Given this list of marker genes SOCS1, UCP2 (NCBI Gene Id 7351), KCNQ1, TEK, IRF7, MYC, FCER1G, CBFA2T3, TFRC, MR1, KMT2A, IFNG, SMAP1, CDK6, EOMES, RHOH, USP44, LEF1, IGHM, ZFPM1, CD8A, DYRK3, DHRS2, MIR145, ARL11, HERC6, XRCC6, TTC7A, MFAP5, LOXL3, TGFBR2, SIRT1, FLNA, SHB, IL1A, BCR, MPL, PPP3CB, PRRC2C, FOXN1, SRC, TMOD3, RAG2, PRKDC, TNFSF8, EXT1, ZBTB7A, TCF3, PITHD1, CDH17, SOX4, FBN1, GAB2, ITGB1, PGLYRP3, IL36B, RC3H1, EVI2B, RAG1, IL23R, DUSP10, BCL6, ZNF160, ITPKB, WNT2B, EPO, SNRK, GPR137B, ADAM10, SPINK5, SH3PXD2A (SH3 and PX domains 2A), CD109, G6PD, IL12B, JAK1, MITF, HES1 (hes family bHLH transcription factor 1), SOS1, LRRC17, CHD2, ITPRIPL1, IL15, QKI, AICDA, SMARCD1, FZD8 (NCBI Gene Id 8325), MALT1, BTK, TNFSF4, CD1D, TPO, ASH2L, EBP, SIGLEC15, IL17D, HCLS1, PTPRJ, PLA2G10, MFAP2, BMP2, STAT5B, GLI2, ACP6, LYAR, BCL3, FOXO3, TREX1, ATF2, ACVR2A, KITLG, ITFG2, ADD2, MEIS1, PPARG, TOX, AGPAT5, DLL4, MFHAS1, CD34, BGLAP, CRIP2, PLA2G3, PIK3R3, EEIG1, RARG, EZH2, SBDS, BAD, TNF, HLX, CARTPT, ACVR1B, FOXC1, FAM20C, NF1, ATP6AP1, DCAF1, SMARCD2, FSTL3, GP9, MYO1E, ACTB, IL2RA, MED1 (mediator complex subunit 1), DMTN, TCIM, FLI1, PRKCA, CEBPA, IL9, BAK1, METTL3, CD79A, IL7R, C1QC, PCID2, IFNB1, IL6ST, SYVN1, LAPTM5, SFRP2, PLCG2, HLA-G, FBXW7, KDELR1, PIK3R2, LEO1, CD164, IL33, LTF, HLA-DOA, SIPA1L3, CCDC134, RPL22, EIF6 (eukaryotic translation initiation factor 6), COX10, SIN3A, LY6D, IL15RA, PTPN6, IRF2BP2, FAXDC2, PNP, ANKLE1, RHOA, RAC2, ARIH2, IL1RL1 (NCBI Gene Id 9173), FSHB, SMAD7, JUN, CCR9, KLF2, MIR222, ID2, PREX1, HIF1A, CTSL, PPP3CA, FBXO21, EIF2AK2, L3MBTL3, ARMC6, WNT3A, SLC46A2, B2M, RIPK1, RC3H2, PRTN3, DNAI4, GLRX5, HEATR3, TSC1, MYSM1, SOCS3, RBM15, WDR38, METTL14, CITED2, FGL2, SMARCE1, ITGB8, ATG5, KIT, BCL2, DHTKD1, LILRB3, TGFBR3, ANLN, IL1B, PTGER4, VPS33B, GFI1B, IRF8, MECOM, PRXL2A, TLR3, BVES, TRIM58, MIR486-1, RIPK3, REST, IL6, ENTPD7, PSEN1, ZNHIT1, GPR68, ZFP36L1, IL18R1, CLEC4D, LDB1 (NCBI Gene Id 8861), RACGAP1, ACIN1, NBEAL2, ADGRF5, THEMIS, CCDC39, CARD11, CD4, TYROBP, TRPM2, EFNA2, MKNK2, H4C9, IL17A, GPR183 (G protein-coupled receptor 183), TMEM176B, MAPK11, SART3, IGHE, FNIP1, CEBPB, POLM, CLEC1B, PTCRA, ADAM8, MEIS3, IHH, SFRP1, MEOX1, GP1BA, NPM1, GPR137, EGR1, PIK3CD, NOTCH4, RBM47, VEGFA, CLEC5A, NDFIP1, RORA (RAR related orphan receptor A), ARID4A, EIF2AK1, KAT5, KLF4, IL27, PIM1, APCS, CD46, CCR2, LARGE1, CTC1, SKIC8 (NCBI Gene Id 80349), NDP, MIR125B1 (NCBI Gene Id 406911), HDAC4 (NCBI Gene Id 9759), ICOSLG, MERTK, TSPAN2, IL1RL2, HIPK2, DPF2, H4C6, HMGB3, NKAP, AGER, CSF3, CD3G, NR3C1, SSBP3, CCR6, FANCA, SASH3, EGR3, RUNX1, CD80, ANG, HMGB2, TESPA1, LGALS3, SLC39A7, TAL1, NFE2L1, KAT7, CD69, FAM3C, IL4R, LEPR, TGFB2, NRROS, SMAD5, GPR89B, VPS33A, EEF2, SLC25A38, FANCD2, SLC1A5, MEIS2, SLC48A1, HLA-DRA, SGPL1, TLR2, TLR9, IL10, NAGLU, PUS7, HEATR9, STAT3, UBD, PHF10, SART1, CDK5RAP3, ANXA2 (NCBI Gene Id 792), GPR18, RABL3, SLAMF6, ATP7A, MYH9, GPR89A, TMSB4X, LFNG, CNOT4, FLT3LG, HOXA9, TMEM64, TNFSF11, SMARCB1, CIB1, GLI3 (NCBI Gene Id 2737), SLC4A2, ZFP36L2, SBNO2, CASP8, HDAC6, TOB2, KLHL25, IL2RG, ERBB2, ZBTB46, LILRB4, HDAC5, HSCB (HscB mitochondrial iron-sulfur cluster cochaperone), IFNA2, IFI16, ETV2, FOXP3, ASCL2, KLF1, TIRAP, LIPA, FZD5 (NCBI Gene Id 81561), CHMP5, CLDN18, ZAP70, RPS19, DOCK2, PRELID1, TCIRG1, TMEM131L, PKNOX1, NFIL3, SNAI2, JAM3, FLCN, EP300, DCSTAMP, TCEA1, ABCB10, SPIB, KCNK18, HSF1, TSPO2, RPA1, IL5, NCOA6, EML1, CTNNB1, ETV6 (ETS variant transcription factor 6), TGFB1, SMARCA4, CD74, TNFRSF11B, SMARCC1, ATM, HYAL2 (hyaluronidase 2), MAF, KLF6, CHD7, JAG1, CR1, IKZF3 (NCBI Gene Id 22806), KDR, LILRB2, ROGDI, CD40LG, OSTM1, WNT10B (NCBI Gene Id 82499), PAFAH1B1, MFSD8, BRPF3, ZBTB24, AHSP, RAC1, GBA1, SLC11A2, GLO1, MDK, LMBR1L, NFKBIZ, MEN1, IL25 (NCBI Gene Id 64806), CD81, SLAMF8, CDKN2B, JAGN1, PDCD2, OGT, BTN2A2, TREM2, TP53, ZNF385A, IGSF23, H4C1, FSHR, CDC73, H4C5, PRDM16, MIR30B, SCIN, ZC3H12A, INHA, ATP5IF1, MMP14, ANXA1, PTBP3, FARP2, PTPRC, H4C3, H4C13, TUBB1, LCK, DCLRE1C (NCBI Gene Id 64421), LIG4 (NCBI Gene Id 3981), RHEX, TOP2A, GATA1, H4C16, PLD4, FCRL3, NTRK1 (neurotrophic receptor tyrosine kinase 1), P2RX5, FCGR2B, RTKN2, JAK2 (NCBI Gene Id 3717), CD19, AXL, IREB2, IL6R, ACE, TCTA, IL3 (interleukin 3), RLIG1, H4C15, TNFRSF11A, IL31RA, ZFP36, TPM4, TMEM178A, PBRM1, LILRB1, GATA3, AZI2, SLC9B2, WDR1, INHBA, PATZ1, STAT5A, KLF10, TNFAIP6 (TNF alpha induced protein 6), IL12RB1, FUT10, CEBPG, NOTCH2, BRD1, YPEL4, PDGFB, CD3E, SFXN1, ASXL1, BRD2, HAX1, ING5, THOC5, BLNK, BRD4, TMEM14C, ITGA4, ZNF784, TAOK3, TCF15, N4BP2L2 (NEDD4 binding protein 2 like 2), THPO, MS4A1, RPTOR, KAT6A, IL18, NOTCH1, WNT5A, JAK3, RIPK2, CIAO3, DNAJB9, MTURN, ZNF675, PABPC4, CEBPD, TRAF6, GPATCH8, ARMC5, HMGB1, IL11, H4C11, TRAF3IP2, JAG2, PGLYRP1, NHEJ1, SMPD3, SMARCA2, SP7, BLVRB, ATF4, GPS2, MB, YY1, ZFAT, BAX, TLR4, GPR171, SRF, FOXJ1, AP3B1, VCAM1, ZBTB16, XBP1, CD86, NFAM1, BMP4 (bone morphogenetic protein 4), RARA, HDAC9, CYP26B1, COA5, RASSF2, LGALS8, CDC42, SERPINB12, RORC, ICOS, SOS2, SLC8A3, SH2B3, MLF1, MEAF6, MMP21, BPGM, ADA, PTK2B, DROSHA, TYRO3, CDIN1, CEACAM1, NRARP, NCKAP1L, CAMK4, ABI1, ADAM17, RRS1, RASGRP1, FBXO7, NKX2-3, CR2, ANKRD54, PLA2G2D, IAPP, PARP1, CLCF1, APP, C17orf99, PRMT6, PLEK, VAV1, MAFB, PGM3, ARID1B, IL34, ITCH, CSF1R, IL21, ALAS1, SEMA4A, LGALS9, BMI1, CTR9, NLRP3, NFATC3, IL20, FAM210B, ATXN1L (NCBI Gene Id 647512), PURB, IRF4, PBXIP1, OSCAR, SH3RF1, RB1, VSIR, PRKCZ, FZD7, CMTM7, WASF2, BATF, LAG3, IL7, HSPA9, ISG15, MEIS3P1, MPIG6B, SHH (sonic hedgehog signaling molecule), MTOR, OSM, PRR7, ZBTB1, MT1G, FGFR2, MYD88, FLT3, ZBTB7B, BBLN, PDGFRA, TMEM91, WNT1, CCL19, CIAPIN1, PHF14, L3MBTL1, BABAM1, F2RL1, ERCC1, LY9, ALAS2, PRDX3, TMEM176A, MAPK14, TRIB1, SOX12, TIFAB, CD27, CCN4, KIRREL3, ABL1, WDR7, NCAPG2, ADGRG3, LIF, HHEX, SRP54, BRPF1, PTPN2, YJEFN3 (NCBI Gene Id 374887), ARID1A, PDE2A, WBP1L, MYB, CCR1, MEF2C, CTNNBIP1, PDE1B, LYL1, KLRC1, ACTN1, CCR7, RNF41, PIAS3, H4C14, RAB7B, LBR, TNFSF13B, KAT8 (NCBI Gene Id 88034), HOXB3, MLLT3, KRT75, CSF1, LEP, YTHDF2, JMJD6, PAF1, SOCS5, PRKX, EPB42, AMBRA1 (autophagy and beclin 1 regulator 1), CDK13, CCL3, FOXP1, SOD2, BATF3, FASN, DDRGK1, ERFE, RELB, HES5, PSG9 (NCBI Gene Id 91052), CLEC12A, ITGB6, ARNT, STAT1, PIK3R6, SPN, CLEC4G, HOXB4 (NCBI Gene Id 3214), ZNF16, KAT2A, UBA5, BATF2 (basic leucine zipper ATF-like transcription factor 2), PICALM, GP5, CDKN1C, CTLA4 (cytotoxic T-lymphocyte associated protein 4), IL4, CASP3, SLC25A5, FECH, CASP9, INPP5D, PCK1, GPR55 (NCBI Gene Id 9290), GATA2, ZNF683, HOXA7, CBFB, GP1BB, IL23A, AP3D1, TESC, ITK, PTPN11, CD83, PIK3R1, EPAS1, LYN (NCBI Gene Id 4067), PBX1, SP3, CLPB, TUSC2, STAT4, PYGO1, PINK1 (NCBI Gene Id 65018), HOXB8, ETS1, HLA-B, STK3, FZD9, FADD, IFNL1, DTX1, EPHA2, TWSG1, TCF7, TET2, CYLD, SMARCC2, SPI1, DACT2, ANGPT1, STK11, MIR221, SOX13, MAEA, GPR65, NFKBID, CLEC4E, CD3D, PDP2, TOP2B, PTPN22, CUL4A, NFKBIA, NFE2L2, TMEM98, GABPA, RCOR1, KLF13, XRCC5, CSF3R, CDKN2A, STK4, NEMP1, PRDM1, TF, DOCK10, PIR, OCSTAMP, ZC3H8, IL4I1, ACTL6B, ACTL6A (NCBI Gene Id 9178), CD79B, HIPK1, OPA1, LRRK1, MIXL1, PTPRZ1, CREB1, ERCC2, BAP1, DOCK11, IFT80, ONECUT1, VPS54, ITM2A, H4C8, CEBPE, JUNB, IRF1, TNFRSF9, PF4, MIR21, SELENOW, IKZF1, H4C4, ESCO2, BCL11B, BRCA2, GAS6, CLPTM1, CD2, DNASE2, TNFSF9, FUT7, PTN, LOX, PSMB11, MELK, ADIPOQ, RBPJ, HBZ, ZMIZ1, TNFRSF13B, FLVCR1, SETD1A, HOXB7, ADAR, NCAPH2, RUNX2 (RUNX family transcription factor 2), FES, SPTA1 (NCBI Gene Id 6708), TM4SF19, TRIM10, DHX36, MIR17HG, VNN1, FOSL2, POU4F2, TBX21 (NCBI Gene Id 30009), KMT2E, ZEB1, MSH2, GAB3, UFL1, PPP2R3C, TFE3, PML, HLA-DRB1, KAT6B, IL2, ST3GAL1, SLC4A1, SLAMF1, GPC3, RPS14, CSF2, PRMT1, DIAPH3, PIP4K2A, NUDT21, NKX2-5, KLF3, CD28, TPD52, MIR223, HSPA1A, PGLYRP2, PAX5, SLC7A6OS, TNFSF18, MFNG, RRAS, STAT6, FOS, BRD7, DNAJA3, SOD1, WNT4 (NCBI Gene Id 54361), CNN2, P4HTM, RHAG, LGALS1, RUNX3, BRAF, TMEM190, CD101, TENT2, ARID3C, LRRC8A, SMARCD3, HSPA1B, POU2AF1, HOXA5, CRACR2A, FST, UBASH3B, VPS13A, RSAD2, SENP1, POU4F1, MMP9, AIRE, RASGRP4, PRDX2, PLCL2, PPARGC1B, HNRNPU (NCBI Gene Id 3192), CALCR, SYK, GLUL, CFLAR, LTBR, DLL1, NEDD9, SLC25A40, CALCA, AQP8, ARID2, TIPARP, THRA, H4C2, CRTAM, H4C12, TSC22D1, SNX10, TBK1, here is a description of the gene set: Human Gene Set: GOBP_HEMOPOIESIS The process whose specific outcome is the progression of the myeloid and lymphoid derived organ/tissue systems of the blood and other parts of the body over time, from formation to the mature structure. The site of hemopoiesis is variable during development, but occurs primarily in bone marrow or kidney in many adult vertebrates. studied in species Homo sapiens